The following is a description of a gene set: from publication Chen Y, Wang X (PMID 31504780) Human Gene Set: MIR9899 Genes predicted to be targets of miRBase v22 microRNA hsa-miR-9899 in miRDB v6.0 with MirTarget v4 prediction scores > 80 (high confidence targets). studied in species Homo sapiens, and this is the list of marker genes: WDR90, NCK2, RALGAPB, GALNT9, PAK6-AS1, ST18